Given this list of marker genes Pfn1, Map3k1, Mdfic, Rsf1, Dhx9, Notch1, here is a description of the gene set: Any process that activates or increases the frequency, rate or extent of viral transcription. species: Mus musculus Mouse Gene Set: GOBP_POSITIVE_REGULATION_OF_VIRAL_TRANSCRIPTION